The following is a description of a gene set: part of: Apoptotic execution phase Reactome Pathway: Apoptosis induced DNA fragmentation This event has been computationally inferred from an event that has been demonstrated in another species.<p>The inference is based on the homology mapping from PANTHER. Briefly, reactions for which all involved PhysicalEntities (in input, output and catalyst) have a mapped orthologue/paralogue (for complexes at least 75% of components must have a mapping) are inferred to the other species. electronically inferred by orthology from the curated human pathway studied in species Mus musculus, and this is the list of marker genes: H1f5, Hmgb2, Kpnb1, Dffa, Kpna1 (NCBI Gene Id 16646), H1f4, Dffb, Hmgb1, H1f1, Casp3 (NCBI Gene Id 12367), H1f3